Given this list of marker genes PIK3R1, MAPK1, MTOR, MAP2K6, PIK3CG, MAP2K1 (mitogen-activated protein kinase kinase 1), PIM2, RPS6, EIF4EBP1, MAPK3, MAP2K4, EIF4A1, EIF4G1, PRKCA, RPTOR, RPS6KB1, RPS6KA1, AKT1, RPS6KA4, RPS6KA2, MAPK9, MAPK10, PIK3CB, PIK3R3, AKT2, PDCD4, EIF4B, MAP2K7, PRKCD, PIK3CA, PIK3R2, PIM1, CSNK2A1, PRKACA, PDK1, EIF4G3, EIF4A2, MAPK14, EIF4E, MAP2K2, RPS6KA5, MAP2K5, MAP2K3, AKT3, RPS6KB2, MAPK8, here is a description of the gene set: Human Gene Set: WP_TRANSLATION_INHIBITORS_IN_CHRONICALLY_ACTIVATED_PDGFRA_CELLS Translation inhibitors in chronically activated PDGFRA cells studied in species Homo sapiens